Given this list of marker genes Fgf6, Cbl, Fgf1, Fgf8, Fgf20, Fgf15 (fibroblast growth factor 15), Fgf16 (NCBI Gene Id 80903), Hras, Fgf23, Frs2, Grb2, Shc1, Gab1, Fgf2, Mapk3, Spry2, Klb, Ubb, Fgf4, Rps27a, Fgf17, here is a description of the gene set: This event has been computationally inferred from an event that has been demonstrated in another species.<p>The inference is based on the homology mapping from PANTHER. Briefly, reactions for which all involved PhysicalEntities (in input, output and catalyst) have a mapped orthologue/paralogue (for complexes at least 75% of components must have a mapping) are inferred to the other species. studied in species Mus musculus Reactome Pathway: Signaling by FGFR4 part of: Signaling by FGFR electronically inferred by orthology from the curated human pathway